The following is a description of a gene set: species: Homo sapiens Gradual, very slow onset of disease manifestations. Human Gene Set: HP_INSIDIOUS_ONSET Insidious onset, and this is the list of marker genes: CACNA1A (NCBI Gene Id 773), NR4A2, SPAST, TBP, WASHC5, NIPA1, MT-TT, ATXN2, ADH1C, ATXN3, ATXN8OS, OPA1, SNCAIP, PMP22, SNCA, MAPT, GBA1, EIF4G1, ATL1, MPZ